The following is a description of a gene set: Any meiotic cell cycle process that is involved in oocyte maturation. species: Homo sapiens Human Gene Set: GOBP_MEIOTIC_CELL_CYCLE_PROCESS_INVOLVED_IN_OOCYTE_MATURATION, and this is the list of marker genes: LSM14B, PPP2R1A, NPR2, NPPC, EDN1, EDNRA, YTHDF2